Given this list of marker genes RAB3C, RAB22A, RAB30, RAB11B, PTP4A2, RAB7B, CHML (NCBI Gene Id 1122), RAB32, RAB35, RAB6A (NCBI Gene Id 5870), RAB1B, RAB7A, RAB20, RAB4B (RAB4B, member RAS oncogene family), RAB21, RAB43, RAB24, RAB9A, RAB19, RAB17, RAB3D, CHM, RAB1A, RAB39A, RAB29, RAB18, RAB27A, RAB26, RAB41, RABGGTA, RAB40B, RAB38, RAB33A, RAB13, RAB10, RABGGTB, RAB40C, RAB25, RAB34, RAB5A, RAB9B, RAB39B, RAB3B (RAB3B, member RAS oncogene family), RAB3A, RAB5C, RAB2A (NCBI Gene Id 5862), RAB23, RAB12, RAB42 (NCBI Gene Id 115273), RAB36, RAB40A, RAB14 (NCBI Gene Id 51730), RAB44, RAB8B, RAB4A, RAB31, RAB27B, RAB5B, RAB2B, RAB6B, RAB37, RAB15, RAB8A, RAB33B, RAB11A, here is a description of the gene set: part of: Post-translational protein modification Human cells have more than 60 RAB proteins that are involved in trafficking of proteins in the endolysosomal system. These small GTPases contribute to trafficking specificity by localizing to the membranes of different endocytic compartments and interacting with effectors such as sorting adaptors, tethering factors, kinases, phosphatases and tubular-vesicular cargo. RAB localization depends on a number of factors including C-terminal prenylation, the sequence of an upstream hypervariable regions and what nucleotide is bound. In the active, GTP-bound form, prenylated RAB proteins are membrane associated, while in the inactive GDP-bound form, RABs are extracted from the target membrane and exist in a soluble form in complex with GDP dissociation inhibitors (GDIs). Conversion between the inactive and active form relies on the activities of RAB guanine nucleotide exchange factors (GEFs) and GTPase activating proteins (GAPs).<br>Newly synthesized RABs are bound by a RAB escort protein, CHM (also known as REP1) or CHML (REP2). CHM/REP proteins are the substrate-binding component of the trimeric RAB geranylgeranyltransferase enzyme (GGTaseII) along with the two catalytic subunits RABGGTA and RABGGTB. REP proteins recruit the unmodified RAB in its GDP-bound state to the GGTase for sequential geranylgeranylation at one or two C-terminal cysteine residues. After geranylgeranylation, CHM/REP proteins remain in complex with the geranylgeranylated RAB and escort it to its target membrane, where its activity is regulated by GAPs, GEFs, GDIs and membrane-bound GDI displacement factors (GDFs). Reactome Pathway: RAB geranylgeranylation studied in species Homo sapiens